Given this list of marker genes DPY19L2, GPC4, HMGB1, P2RY13, TUT7, ZNF615, STK17A, PELI2, CALN1, RAB10, SMARCAD1, DHH, UBE4A, CHRNE, CYP27B1, CMPK1, GNPNAT1, CDON, CANX, MN1, MIB1, ATP11A, MAP3K8, IDE, POU2F2, RAB41, SNRNP70, here is a description of the gene set: from publication Chen Y, Wang X (PMID 31504780) Genes predicted to be targets of miRBase v22 microRNA hsa-miR-3677-5p in miRDB v6.0 with MirTarget v4 prediction scores > 80 (high confidence targets). studied in species Homo sapiens Human Gene Set: MIR3677_5P